Given this list of marker genes Tmbim6, Ppp1r2, Col2a1, Tacr3, Asns, Sod2, Cdkn2b, Parp2, Apom, Ephx1, Tars1, Clcn2, Dnajb1, Bsg, Slc25a4, Ykt6, Fgf18, Eif5, Pdap1 (NCBI Gene Id 231887), Ctsl (cathepsin L), Htr7, Atp6v1c1, Ggh, Msx1, Aqp3, Irf1 (NCBI Gene Id 16362), Psmc3, Bmp2, Rpn1, Nptxr, H2ax, Amd1, Atf3, Atp6v1f (ATPase, H+ transporting, lysosomal V1 subunit F), Il6, Lhx2, Fkbp4, Pole3, Fmo1, Gch1, Ddx21, Btg3, Klhdc3, Nfkbia, Urod, Pdlim3, Cyb5r1, Hyal2, Cyp1a1, Epcam, Alas1, Mrpl23, Nptx2, Slc6a12, Prpf3, Nxf1, Cck, Olfm1, Gpx3 (glutathione peroxidase 3), Hmox1, Kcnh2, Nup58, Cdc34 (cell division cycle 34), Prkaca, Grina (glutamate receptor, ionotropic, N-methyl D-aspartate-associated protein 1 (glutamate binding)), Polr2h, Nr4a1, Mark2, Dgat1, Wiz, Chka, Fos, Cxcl1, Creg1, Ppat, Cebpg, Ppt1, Mmp14, Sigmar1, Sult1a1, Stk25, Tyro3, Ntrk3, Fosb, Rasgrp1, Dnaja1, Cdkn1c, Eno2, Rhob, Ap2s1, Furin, Hspa13, Acaa1a, Prkcd (protein kinase C, delta), Car2, Tchh, Slc6a8, Bcl2l11, Btg1, Lyn, Spr, Ccne1 (cyclin E1), Cdk2, Shox2, Casp3, Ptprd, Hspa2, Fen1, Aldoa, Arrb2, Rrad, Dlg4, Abcb1a, Ccnd3, Tfrc, Grpel1, Cdc5l, Cyb5b, Cltb, Igfbp2, Tuba4a, Ago2, Rab27a, Plcl1, Icam1, Sqstm1, Tst (thiosulfate sulfurtransferase, mitochondrial), Polg2, Gls, Bid, Ppif (NCBI Gene Id 105675), Tap1, Gal, Cdo1 (NCBI Gene Id 76278), Eif2s3x, Cnp, Btg2, Hnrnpu, Stip1, Onecut1, Nat2, Chrna5, Rfc4, Il6st, Stard3, Selenow, Maoa, Mapk8ip2, Mgat1, Tgfbrap1, Rxrb, Nkx2-5, Bak1, Ret, Junb (NCBI Gene Id 16477), E2f5, here is a description of the gene set: studied in species Mus musculus Mouse Gene Set: HALLMARK_UV_RESPONSE_UP from publication Howe DG, Blake JA, Bradford YM, Bult CJ, Calvi BR, Engel SR, Kadin JA, Kaufman TC, Kishore R, Laulederkind SJF, Lewis SE, Moxon SAT, Richardson JE, Smith C (PMID 30224793) Mouse genes annotated to HALLMARK_UV_RESPONSE_UP based on orthology mappings provided by the Alliance Genome Consortium